Given this list of marker genes PAPPA2, CD24, IGFBP6, CXCL14, S100A10, MUC1, MMP7, PERP, KRT7 (NCBI Gene Id 3855), S100A4, SLC12A1, TACSTD2, TIMP1, CA4, S100A11, KRT19, CLDN10 (claudin 10), ANXA2, SLPI, KRT17 (NCBI Gene Id 5103), IGFBP2 (insulin like growth factor binding protein 2), S100A6, TSPAN1, TSPAN8, TM4SF1, S100A2, ITM2C, SOD3, CLDN7, PTH1R (NCBI Gene Id 5745), PCSK1N, CLDN16, S100A14, SOD2, MAL, IFITM3, S100A9, KNG1, ADIRF, LY6E, CLU, WFDC2, HLA-B, LGALS3, ACP3, MGLL, CD74, DEPTOR, ANXA1, ATP1B1, here is a description of the gene set: Genes upregulated in subsets of cells of a given type within various tumors Human Gene Set: GAVISH_3CA_METAPROGRAM_EPITHELIAL_EPI_2 from publication Gavish A, Tyler M, Greenwald AC, Hoefflin R, Simkin D, Tschernichovsky R, Galili Darnell N, Somech E, Barbolin C, Antman T, Kovarsky D, Barrett T, Gonzalez Castro LN, Halder D, Chanoch-Myers R, Laffy J, Mints M, Wider A, Tal R, Spitzer A, Hara T, Raitses-Gurevich M, Stossel C, Golan T, Tirosh A, Suvà ML, Puram SV, Tirosh I (PMID 37258682) species: Homo sapiens In this study, an extensive analysis was conducted to define meta-programs (MPs) capturing intra-tumor heterogeneity across a spectrum of tumor types. The approach utilized non-negative matrix factorization (NMF) to analyze each cell type separately within individual tumor samples. This involved the analysis of malignant cells, macrophages, fibroblasts, endothelial cells, epithelial cells, T-cells, and B-cells. NMF was executed with varying parameter values (K=4, 5, 6, 7, 8, 9), thereby generating 39 programs for each cell type per sample. Each NMF program was summarized by the top genes based on NMF coefficients.\nRobust MPs were then delineated for each cell type using a set of stringent criteria, including recurrence within the same tumor, similarity to programs in other tumors, and non-redundancy within a tumor. Subsequently, these robust NMF programs were clustered (per cell type) based on Jaccard similarity, leading to the identification of MPs associated with each cell type.\nTo enhance the quality of the MPs, a refinement steps were undertaken, involving the removal of MPs suspected of reflecting low-quality data (with an overrepresentation of ribosomal proteins or mitochondrial-encoded genes), single-study inclusion, or similarity to miss-annotated cell types.